The following is a description of a gene set: Genes having at least one occurence of the motif AGGGCAG in their 3' untranslated region. The motif represents putative target (that is, seed match) of human mature miRNA hsa-miR-18a* (v7.1 miRBase). species: Homo sapiens Human Gene Set: AGGGCAG_MIR18A, and this is the list of marker genes: RAPH1, DLC1, SETD7, KXD1, CAMKV, DLEC1, CIT, CPLX2, RPRD1B, CBX7, ZFYVE27, TRIM25, PCDHAC1, REDIC1, KDM2A, FMR1, PHC2, PCDHA6, ST8SIA2, CSNK2A2, ARID1A, ZC3H10, BCL2L1, ZBTB4, NAA50, PXN, PCDHA13, ENSA, CRCP, STAT3, VDR, QKI, AP3S2, WASF2, MAPT, PCDHA5, PCSK6, JPH4, URGCP, MBNL2, OGT, MAPKBP1, DCUN1D3, ZCCHC14, KCNH3 (potassium voltage-gated channel subfamily H member 3), LMX1A, PIP4P1, SETD2, PBRM1, KHNYN, AGPAT4, PCDHA7, TIMP2, GYS1, PCDHA8, SMPD3, HOXD4, STRADA (NCBI Gene Id 92335), EMX1, MAT2A (methionine adenosyltransferase 2A), TTLL3, EPHB3, PCDHA12, TET2, HOMER2, BCKDK, ZFYVE1, PCDHA1, DAG1 (NCBI Gene Id 1605), CITED2, PDP1, ATF7, MXD4, STOML1, GLP1R, IGF2BP1, SEMA4G, RNF40, PCDHA4, EIF4ENIF1, PCDHA3, FURIN, LHX6, CCDC88B, BAHD1, USB1, CTDP1, RAD23B, HMGN5 (NCBI Gene Id 79366), HIRA, CALM3, PAK3, PAN3, ZNF644, NDEL1, PCDHA10, FSTL4, LRRC8A, TACC1, UBE2Z, E2F1, CYFIP2, PRELID1, PCDHA11 (NCBI Gene Id 56138), ESR1, ZC3H12B, RUNX1, ENC1, SLC8A2, PPP4R3A, CSNK1D, SRSF7, HIC2, TMEM241, YWHAZ, GOT2, ITGB3, PCDHA2, GATA2, PCDHA9, FAM53C, TRAF7, NF2, ARL4C, SERTAD2, TRIB2, ETV5, PSD, TTBK1, MAPK8IP3, PCDHAC2, IL17RB (NCBI Gene Id 55540), SLC38A4, SNX27, TLN2, PFKFB4, CREB1, RASL10B